Given this list of marker genes TBCD, ALG2, NKX6-2, GJC2, POLR1C, DDOST, SIGMAR1, PIGW, GRIK2, PIGY, EXOSC5, DALRD3, PEX13, GRM7, PGAP3, FBXL4, SLC25A12, PIGV, TRAPPC11, SMPD4, EXOC2, CLDN11, LEMD2, WDR26, TIAM1, GABRA2, HYCC1, PYCR2, EIF2B1, AHDC1, RARS1, NARS2, ELOVL1, STXBP1, GDAP1, PGAP2, PIGL, QARS1, DYRK1A, RMND1, SPTAN1, PHGDH, GLUL, STAMBP, SOX10, PI4KA (phosphatidylinositol 4-kinase alpha), NMNAT1, IFT56, TUBB4A, AHCY, VPS11, C2CD3, INTU, AFG2A, TMTC3, EPRS1, GAN, MTHFS, FUCA1, SPG11, PLP1, SLC33A1, CNTNAP1 (contactin associated protein 1), DARS1, SNIP1, C2orf69, SPTLC1, BCAP31, HEXB, ADSL, POLR1A, DPAGT1, PIGO, GABRA5, FUS, ACBD5, PIGA, AARS1, PARS2, CHKA, MED27, YIF1B, CYB5A, NOP10, POLR3B, PRKDC, ALS2 (alsin Rho guanine nucleotide exchange factor ALS2), POLR3A, PURA, RNF220, SLC1A4, ATP6V1A (ATPase H+ transporting V1 subunit A), CYB5R3, here is a description of the gene set: species: Homo sapiens Human Gene Set: HP_CNS_HYPOMYELINATION CNS hypomyelination Reduced amount of myelin in the central nervous system resulting from defective myelinogenesis.